Given this list of marker genes Polr2c, Eaf1, Nelfe, Polr2k, Eaf2, Ercc3, Tcea1, Supt16, Polr2l, Mllt1, Gtf2h2, Ercc2, Gtf2f1, Supt4a, Ctdp1, Gtf2f2, Polr2e, Supt5, Aff4, Ccnh, Gtf2h4, Nelfa, Polr2b, Polr2i, Ctr9, Leo1, Iws1, Polr2f, Polr2a, here is a description of the gene set: Reactome Pathway: Formation of RNA Pol II elongation complex part of: RNA Polymerase II Transcription Elongation This event has been computationally inferred from an event that has been demonstrated in another species.<p>The inference is based on the homology mapping from PANTHER. Briefly, reactions for which all involved PhysicalEntities (in input, output and catalyst) have a mapped orthologue/paralogue (for complexes at least 75% of components must have a mapping) are inferred to the other species. electronically inferred by orthology from the curated human pathway studied in species Mus musculus